The following is a description of a gene set: studied in species Mus musculus The directed movement of dehydroascorbate into, out of or within a cell, or between cells, by means of some agent such as a transporter or pore. Dehydroascorbate, 5-(1,2-dihydroxyethyl)furan-2,3,4(5H)-trione, is an oxidized form of vitamin C. Mouse Gene Set: GOBP_DEHYDROASCORBIC_ACID_TRANSPORT, and this is the list of marker genes: Slc2a5, Slc2a7, Slc2a1, Slc2a10, Slc2a8, Slc2a9, Slc2a3, Slc2a2, Slc2a4, Slc23a1